Given this list of marker genes NDUFS2, ANP32B, IDH3G, NDUFS3, SNRNP200, SDHA, GNB2, PPP1CA, HADHA, SRP14, TTC1, EIF1AX, COPS6, EIF3M, COX5B, EIF3E, AP3D1, SMC1A, LSM2, CSNK2B, NDUFS5, PTBP1, HNRNPM, HNRNPA3P1, SH3BGRL, TCEA1, SNRPD2, AK2, PGK1, RAB8A, MRPL9, PDHB, EFCAB14, HDGF, VPS52, TEX261, MACROH2A1, TRAPPC3, SRP9, H2AZ1, XPO7, IMPDH1, PARK7, ERP29, LYPLA1, ERH, EIF3K, CDC37, PSMB2, CTBP1, DEK, DR1, RNF44, SF3A2, MTDH, SET, TATDN2, CDC123, GPAA1, UCP2, BAG6, COX4I1, CTDNEP1 (NCBI Gene Id 23399), UQCRC2, NARS1, RPN1, UQCRFS1, XRCC6, G3BP2, SF3B2, ACTR2, PPIE, PKN1, RAN, GDI2, ANAPC5 (NCBI Gene Id 51433), FBXO9, TMED9, POLE3, RNPS1, DDX39B, PSMB1, UBE2N, SDHD, GUSB, DDX49, NDUFC1, HDAC1, ANP32A (NCBI Gene Id 8125), KHDRBS1, ATP5MC3, U2AF1, ATP5MC1, TAF11, CAPZA1, ILF3, MRPS12, CHERP, IFRD1, EIF3H, NONO, SRRM1, EIF3D, EIF3G, EIF4A1, NDUFS4, TADA3, NDUFV2, NSDHL, PRPF8, H2AZ2, RBMX, TLK1 (NCBI Gene Id 9874), TIAL1, GNB1, CLTA, VDAC2, FAM168B, HMGN1, HAX1, TUFM, SYPL1, PTGES3, R3HDM1, ATXN10, XPO1, EIF4H, GPN1, NDUFV1, RPL14, SUMO1, HDAC2, HNRNPC, GANAB, AKR7A2, CS, CYC1, CHMP2A, KARS1, UBE2L3, DKC1, HNRNPD, TRIM28 (tripartite motif containing 28), BUB3, SDHB, RAD23A, WDR1, POLA2, MED12, ATP5PO, UBAC1, SRSF3, SUMO2, DGKZ, DUT, GNG5, DDX19A, SMARCD2, ACLY, COX6A1, MAP3K11, PCMT1, SLC25A3, UQCRH, BTF3, FUS, PDIA6, HADHB, STARD7, VDAC3, PAPSS1, CHD4, BAZ2A, ARPC2, PPP2R1A, CAP1, HSPD1, SRSF9, HMGB2, NUDT1, SNRPA, VBP1, HNRNPU, PSMB7, CCNI, COX7C, SRSF2, PHB2 (prohibitin 2), CIAO1, ARF3, PRRC2C, NRDC, VPS26A, YWHAQ, KXD1, COPS5, ATP6AP1, SUMO3, SNRPE, DNAJC8, EID1, CBX3, CALM3, FAM120A, SETD3, DRG1, YWHAB, DIAPH1, COPE, LSM7, DDOST, RBBP4, SREBF2, ATP5PF, HNRNPA2B1, ATP5F1D, TCP1, CSK, HNRNPAB, SNX3, MDH1, UBA2, CCT2, EDC4, SCAMP3 (NCBI Gene Id 255017), CANX, NCL, COX6B1, PPM1G, TRA2B, ACP1, NDUFA7, DYNLL1, HNRNPUL1, PUF60, SF3A1, XRCC5, JTB, YWHAZ, EIF4EBP2, AP1B1, ATP5F1A (ATP synthase F1 subunit alpha, NCBI Gene Id 502), AP3S1, AFG3L2, CCT7, HNRNPR, NACA, UBE2D2, MGRN1, TARDBP, PPP1CC, IFT25, IDH2, UQCRB, here is a description of the gene set: Human Gene Set: MORF_HDAC1 studied in species Homo sapiens Neighborhood of HDAC1 Neighborhood of HDAC1 histone deacetylase 1 in the MORF expression compendium